Given this list of marker genes DDC, PNMT, TH, DBH, here is a description of the gene set: The catecholamine neurotransmitters dopamine, noradrenaline and adrenaline are found in nervous tissue of animals. They are synthesized in catecholaminergic neurons by four enzymes from tyrosine to adrenaline: tyrosine hydroxylase (TH); aromatic L-amino acid decarboxylase (AADC); dopamine beta-hydroxylase (DBH); and phenylethanolamine N-methyltransferase (PNMT). Reactome Pathway: Catecholamine biosynthesis species: Homo sapiens part of: Metabolism of amine-derived hormones